Given this list of marker genes MCM7, YAP1, OTX2-AS1, KIF2A, FANCI, TRIM59, CELSR1, SMC4, BARD1, VIT, CNPY1, CHN2, TOP2A, VSTM2L, CKS1B, MIR99AHG, AJUBA, FZD2, FANCB, PMAIP1 (NCBI Gene Id 9305), CDH2, CAP2, RPL23A, NPY, MID1, DEPDC1 (DEP domain containing 1), SIVA1, ZMAT4 (NCBI Gene Id 79698), TCF3, TROAP, CDCA3, TTK, SNORD73A, KIF18A, BUB1B, RCN1, SFXN2, CCN2, PIP5K1B, CCNB2, UHRF1, COL2A1, PLOD2, SALL4, SKA3, OTX2, MDK, TPX2, SLIT2, ESCO2, DDC, KNSTRN, FZD3, SPDL1, RAD51AP1, PDZRN3, KIF14, MT1X, HMGN2, PTTG1, KLHDC8B, CEMIP2, ZEB2, CDC25A, EFNA5, FOXA1, DSC2, BDH2, CEP152, TSPAN18, SYT2, BIRC5, C21orf58, RBM24, H2BC9, GPSM2, RAI14, RNASEH2A, SPC25, GASK1B, PTGR1, ZFHX3, VIM, AP5M1, ARX, GNG5, WEE1, PARPBP, NUSAP1, RRM2, NAXE, IGDCC3, CDK2, DHFR, LTBP1, ZFP36L2, UBE2T, SLC39A8, DENND11, NUDT4, TSPAN19, ATAD5, LIPG, ECT2, FBLN1, KIF15, PLEKHA5, LMX1A, CDCA5, RPS14, EPHB2, FZD1, TPBG, MYBL2, NUF2, STK17B (NCBI Gene Id 9262), MELK, TACC3 (transforming acidic coiled-coil containing protein 3), CCN1, SALL1, DLGAP5, TET1, CENPW, H4C6 (NCBI Gene Id 8361), KIF4A, DMRTA2 (NCBI Gene Id 63950), UBE2C, SGO2, GPRC5C, B3GNT5, CDC25C, FBN1, TOX3, ATAD2, CCNA2, HMGA1, SLF1, SMAD6, WNT5A, CENPE, AURKB, TRABD2B, JPT2, MEST, LMX1B, LRATD2, PRTG, SNORA18, KIF2C, NELL2, PRR11, H2AX, FBXL7, ELOVL2, AK4, PSRC1, DBF4, TMPO, RFC3, TWIST1, SMC2, PIMREG, IGF2BP3, RPL13AP5 (NCBI Gene Id 728658), PTPRO, CCDC8, TCF12, GTSE1, SHROOM3, LMNB2, RFX4 (NCBI Gene Id 90489), ENKUR, CENPU, TFF3, JAM2, LOXL4, MND1, HES1, HMGA2, SPAG5, KIF23, H3C3 (H3 clustered histone 3), VEPH1, C22orf15, DEK, EZH2, IGF2BP1, LGI1, PBK (PDZ binding kinase), CHRDL1, ASPM, PIF1, MIS18BP1, LRP2, CDCA8, PTX3, TMEM132C, LSM4, TYMS, BMP7, GPX8, KIF22, MCM3, NECTIN3, CRB2, ARHGEF26, NEK2, ARL4A, SOX2, FOXA2, REST, SDC1, ZWINT, HELLS, FNDC3B, RCOR2, CKAP2, ITGB3BP, ANLN, NES, FOXM1, NCAPH, ADAMTS6, CDKN3, MASTL, PTPRK, MAT2B, CTNNAL1, SNRPB, ACVR2B, SOX21, BRCA1, GPC4, CENPV, RPA3, EEF1D, PDGFC, FBXO5, CRYZ, RPS19, GINS2, LMNB1, HMMR, ZFP36L1, TXLNB, TMEM123, SGO1, PHGDH, VRK1, GINS1, CENPF, CDK6, PLK1, SRF, POU3F1, CLSPN, HJURP, CDK1, GULP1, BUB1, WNT7A, CNTN6 (contactin 6), GBX2, AURKA, NCAPD2 (non-SMC condensin I complex subunit D2), PRC1, BRCA2, MSI1, IGFBP2, CNTN4, NRCAM, TENM4, GMNN, FREM1, TIMELESS, H3C2, AASS, DOK1, MACROH2A2, DIS3L2, CNN2 (calponin 2), DEPDC1B, TMSB15A, EFS, NKD1, HK2, EN2, MMRN1, RTKN2, FREM2, CHAF1A, NCAPG, RANBP1, MAD2L1, MCM6, CCNB1, HMGB2, KNL1, PROM1, CHEK1, TK1, TSPAN11 (tetraspanin 11), FAM83D, DSG2, CKAP2L, H4C11, DIPK2A, FAM72A (family with sequence similarity 72 member A), CCND1, CYYR1, JAM3 (junctional adhesion molecule 3), MKI67, SDC2, TMEM47, CENPN, CALML4, KIF11, KCNQ2, STON1, WNT1, MCM2, SFRP2, here is a description of the gene set: Cell types are named using anatomical and functional mnemonics prefixed by 'm' or'h' to indicate mouse and human respectively: OMTN, oculomotor and trochlear nucleus; Sert, serotonergic; NbM, medial neuroblast; NbDA, neuroblast dopaminergic; DA0-2, dopaminergic neurons; RN, red nucleus; Gaba1-2, GABAergic neurons; mNbL1-2, lateral neuroblasts; NbML1-5, mediolateral neuroblasts; NProg, neuronal progenitor; Prog, progenitor medial floorplate (FPM), lateral floorplate (FPL), midline (M), basal plate (BP); Rgl1-3, radial glia-like cells; Mgl, microglia; Endo, endothelial cells; Peric, pericytes; Epend, ependymal; OPC, oligodendrocyte precursor cells. Human Gene Set: MANNO_MIDBRAIN_NEUROTYPES_HPROGFPL species: Homo sapiens from publication La Manno G, Gyllborg D, Codeluppi S, Nishimura K, Salto C, Zeisel A, Borm LE, Stott SRW, Toledo EM, Villaescusa JC, Lönnerberg P, Ryge J, Barker RA, Arenas E, Linnarsson S (PMID 27716510)